Given this list of marker genes JOSD1, SLC35A2, SRPK2, RHOT1, STARD8, ATG12, UBQLN1 (ubiquilin 1), NANP, DEFB132, CCPG1, C17orf75, INO80D, DCC, PPM1B, GPC5, DUOX2, PTMA, KCNH5, SERPINB9, TRHDE, TMPRSS13, REG1A, BBS4, SINHCAF, HLTF, CTNNB1, NUDT18, DDX6, PKD2, TESMIN (testis expressed metallothionein like protein), PHF6, CCDC167, RIMS1, ESYT2, XKR6, NUP153, MPPED1, GNL3L, HSPA12A, RIBC1, KNL1, ATRX, PRR14L, KCNC1, MMGT1, DMXL2, SLC22A3, SNAP91, CAMK2B, PTPN7, SHQ1, CRK, DCAF17, SUCNR1, RINT1, ACOX1, GAPT, EFCAB5, BAZ2A, here is a description of the gene set: Human Gene Set: MIR512_5P species: Homo sapiens Genes predicted to be targets of miRBase v22 microRNA hsa-miR-512-5p in miRDB v6.0 with MirTarget v4 prediction scores > 80 (high confidence targets). from publication Chen Y, Wang X (PMID 31504780)